The following is a description of a gene set: species: Homo sapiens Degradation of beta catenin from publication Schaefer CF, Anthony K, Krupa S, Buchoff J, Day M, Hannay T, Buetow KH (PMID 18832364) Human Gene Set: PID_BETA_CATENIN_DEG_PATHWAY, and this is the list of marker genes: CSNK1D, APC, SSPOP, LRP6, AXIN1, CTNNB1, WNT3A, FZD5, AXIN2, GSK3A, DVL3, SKP1, CSNK1A1, CSNK1E, GSK3B, DVL2, CUL1, DVL1